Given this list of marker genes LAGE3, FKBP6, SLC12A1, GATA3 (NCBI Gene Id 84828), IL10, ADA, WAS, DNAJC30, VHL, NOS1AP, ERAP1, BANK1, NOP10, MT-CO3, OSGEP, ETS1 (NCBI Gene Id 2113), IL6, AMMECR1, HNF1B, SOX18, REN, TMEM270, SDHB, PMM2, IL23R, GTF2IRD2, C3, JAK1, PXK, COQ6, NF1, ARHGAP24 (NCBI Gene Id 83478), BUD23, SDHD, PRTN3 (NCBI Gene Id 5657), BCS1L, MT-TK, KLRC4, PRKCD, APOL1 (apolipoprotein L1), DNASE1L3, MT-TV, PBX1, VPS37D, MMACHC, EPAS1 (NCBI Gene Id 2034), PLCE1, TPRKB (NCBI Gene Id 51002), FCGR3B, ELN, MAX, GTF2I, VPS33B, NUP107, NPHS2, MUC1, NPHS1, FCGR2A, IL12A, MT-TS2, ANLN, CD151, PGM3, NEK8, GTF2IRD1, MME, YRDC, ACE, MT-CO1, MDH2, CFHR5, HLA-DRB1, PDCD1, LAMC2, MT-ND3, TRPC6, FCGR2B, METTL27, SEC61A1, DCDC2, NPHP4, MTX2, SLC37A4, NUP205, VPS33A, IFT122, AGT, LAMA5, SCARB2, MMUT, ALMS1, MRPL3 (NCBI Gene Id 11222), UBE2L3, MYOCD, JAG1, IGHG1, SLC22A12, MT-ND1, COL4A4, BSND, DNMT3A, DNASE2, DNASE1, WT1, STAT4, TBL2, JAZF1 (NCBI Gene Id 94314), MT-ND6, NUP37, HLA-DPA1, CEP83, SLC7A7, LMNB2, TLR7, G6PC1, INVS, FAN1, CR2, DGKE, C4B, MT-ATP6, PUS3, FAH, MYO1E, IRAK1, FOXP3, FASLG, BAZ1B, MT-TH, KCNJ1, C4A (complement C4A (Chido/Rodgers blood group)), FOXC2, ACP5, UBAC2, MT-CO2, IL12A-AS1, SLC2A9, SLC30A9, AGTR1, ANKFY1, CTNS, CD81, HLA-DPB1, SLC41A1, WDR19, INF2, RNU7-1, MAGI2, SDHC, LPIN2, WIPF1, LAMB3, NAA10, TNFSF4, NPHP1, WDR73, MIF, AVIL, CLCNKB, NARS2, TRAF3IP1 (TRAF3 interacting protein 1), LAMA3, KANK2, PAX2, MTRR, HLA-B, C1QA, ZAP70, MT-TL1 (mitochondrially encoded tRNA-Leu (UUA/G) 1), LAMB2, CPT2, LIMK1, FH, BLK, CLCN5, FAS, NCF1, XPNPEP3, ANTXR1, DAAM2, KIRREL1, TAPBP, COQ8B, MT-TW (mitochondrially encoded tRNA-Trp (UGA/G)), CLIP2, MT-ND5, ITGB4, COQ2, NDUFAF6, PTPRO, NUP93, DLST (NCBI Gene Id 1743), COL4A3, NUP133, TMEM127, MMP1, GON7, TP53RK, TNIP1, CASP10, GLA, APOE, WDR4, UMOD (uromodulin), SHPK (NCBI Gene Id 23729), ELP1, CTLA4, IFNGR1, LMNA, MEFV, CFI, RET, SPP1, CD2AP, TREX1, TMEM67, SOCS1, ARPC5, TRIM8, EMP2, FN1, ACSL4, EIF4H, MRPS22, DPH2 (diphthamide biosynthesis 2), OCRL, TNFAIP3, COL7A1, MECP2, MT-TQ, IRF5, ITGAM, DPH1, PLEC, KCNE5, CCR1, GAPVD1, SGPL1, ITGA3, ZNFX1, SLC12A3, GLIS2, TBC1D8B, SMARCAL1, TLR4, SDHAF2 (succinate dehydrogenase complex assembly factor 2), CFH, COPA, PTPN22, MT-TF (NCBI Gene Id 4558), COL4A5, LMX1B, STX1A, GBE1, SLC25A11, NUP160, PKHD1, CRB2, ACTN4, ARHGDIA, MT-ND4, RPGRIP1L, KIAA0319L, KIF1B, NUP85, SDHA, TULP3, DKC1, SPRY2, BTNL2, NPHP3, MT-ND2, RFC2, LACC1, here is a description of the gene set: Abnormal nephron morphology species: Homo sapiens A structural anomaly of the nephron. Human Gene Set: HP_ABNORMAL_NEPHRON_MORPHOLOGY